The following is a description of a gene set: Human Gene Set: HP_ABNORMAL_GLIAL_CELL_MORPHOLOGY studied in species Homo sapiens Abnormal glial cell morphology An abnormality of the glia cell., and this is the list of marker genes: IDH2, CDKN1A, GBA1, MLH1, COX15, MSH6, TARDBP, COQ4, ADNP, GRN, ETFDH, DNAJC13, SQSTM1, TP53, TEFM, POLD1, SEMA4A (NCBI Gene Id 64218), BCS1L, TYROBP, EHMT1, ATP6V1A, GLS, ATXN3 (NCBI Gene Id 4287), YY1, CCM2, MDM2, TREM2, APC, ATM, VPS35, BMPR1A, CYP27A1, MAPT, MOCS1, MAN2B1, CHEK2, DTYMK, HTT, PRKN, THOC2, NARS2, MOCS2, IDH1, EIF4G1, KRIT1, TBCD, SMO (smoothened, frizzled class receptor), SLC30A10, POLE, FUS, MT-TT, PIGA, KARS1, AP4M1, EIF4A2, TBK1, CNTN2, CHMP2B, CDKN1B, FARS2, PLA2G6, NAXD, PAX2, ERBB2, ZNF335, AKT3, ZFTA, AVP, KCNT1, SNCA, NGLY1, FBXO7, CDKN2A, ABCB7, ATXN2, NSD1, MSH3, MTOR, RPS20, LONP1, UBQLN2, KMT2C, EIF2B1, SNCAIP, ADAR, KDM3B, GIGYF2, NUP62, RNU4-2, TLR3, LRPPRC, VCP, PMS1, PSEN1, ARX, APC2, IFNG, EPCAM (epithelial cell adhesion molecule), KRAS, PMS2, NDUFS8, MEN1, SERPINI1, CSF1R, ETFB, NF2 (NCBI Gene Id 654093), TFG, ESAM, LAMA2, ADH1C, FGFR1, VRK1, HSD17B4, PTEN, MT-ATP6, ETFA, SCO2, CHCHD10, BRCA2, PRNP, SETBP1, PMPCA, PLP1, TMEM106B, RANBP2, NUP54, CDKN2C, BRAT1, TSC1, POLG (DNA polymerase gamma, catalytic subunit), NBN, MUTYH, CDKN2B, STRADA, TSC2, C9orf72, MSH2, SLC25A46, GDAP2, NF1, NR4A2, TGFBR2, TSEN54, PDHA1, PIK3CA, TBP, LRRK2, PDCD10, SPRED1, DYRK1A, AIFM1, ERCC8, ATXN8OS, L2HGDH, ERCC6